The following is a description of a gene set: species: Mus musculus Mouse Gene Set: chr2F2, and this is the list of marker genes: Gm14051, Rpl23a-ps4, Lamr1-ps1, Prnd, Bmp2, Gpcpd1, Gm14095, Gm14052, AU019990, Pcna, Gm14103, Trmt6, Cds2, Gm14099, Gm14097 (NCBI Gene Id 102633833), Gm25704, Mcm8, A430048G15Rik (RIKEN cDNA A430048G15 gene), Prokr2, Hao1, Tmem230, Crls1, Gm27449, Gm14101, Gm14100, AV099323, Fermt1, Gm14094, Prnp, Rassf2, Mir3090, Tmx4, 4921508D12Rik, Gm14102, Lrrn4, Shld1, Chgb, Gm14098, Prn, Gm22245, 1700026D11Rik, Slc23a2